Given this list of marker genes EXT2, STT3A, TAP1, INSIG2, TMEM258, NPLOC4, OS9, HSD17B12, PIGK, SPCS1, PPIB (peptidylprolyl isomerase B), STT3B, SYVN1, ALG13, DAD1, CAMLG, NBAS, ELOVL6, PRKCSH, HM13, OSTC, TAPBPL, DNAJB11, PIGP, MAP3K5, SRPRA, HSP90B1, FAF1, TUSC3, RP9, TRAF2, SPCS3, ERN1, P4HB, KRTCAP2, SRP9, SELENOS (selenoprotein S), RNF139, DPM2, RNF125, ERN2, SEC61G, EMC6, UGT3A2, DERL1, FAF2, POMT1, MARCHF6, EMC4, HSPA5, CALR, UBXN1, PLN, RYR1, FKBP1A, PDIA3, UGT1A1, HERPUD1, PIGM, RINT1, GANAB, OST4, EMC8 (ER membrane protein complex subunit 8), SEC61A1, EMC7, PDIA6, SEC11C, GET1, PIGQ, HLA-A, PIGA, EMC1, PIGT (NCBI Gene Id 94004), ARL6IP1, PIGH, TAPBP, PIGY, AMFR, SSR4, SEC63, DNAJC10, AFG2B, MMGT1, SEC61A2, SPCS2, RPN1, MAGT1, FAM8A1 (family with sequence similarity 8 member A1), VCP, MZB1, SREBF2, B2M, PIGU, RPN2, EMC2 (ER membrane protein complex subunit 2), MLEC, UFD1, UBE2J1, PIGS, SEC11B, P4HA1, ZW10, SEC61B, UGT3A1, EMC3 (NCBI Gene Id 55831), GET3, EMC10, PIGC (NCBI Gene Id 5279), SRPRB, EMC9, SDF2L1, TAP2, TREX1, UBXN7, ALG14, GPAA1, DDOST, HYOU1, INSIG1, SEL1L, SEC11A, here is a description of the gene set: A protein complex that is part of an endoplasmic reticulum. Human Gene Set: GOCC_ENDOPLASMIC_RETICULUM_PROTEIN_CONTAINING_COMPLEX studied in species Homo sapiens